The following is a description of a gene set: Mouse Gene Set: GOBP_POSITIVE_REGULATION_OF_MEMORY_T_CELL_DIFFERENTIATION Any process that activates or increases the frequency, rate or extent of memory T cell differentiation. studied in species Mus musculus, and this is the list of marker genes: Pck1 (NCBI Gene Id 98888), Il23a, Tnfsf4, Cd46, H2-Ea